The following is a description of a gene set: Human Gene Set: GOBP_PLATELET_DENSE_GRANULE_ORGANIZATION species: Homo sapiens A process that is carried out at the cellular level which results in the assembly, arrangement of constituent parts, or disassembly of a platelet dense granule. A platelet dense granule is an electron-dense granule occurring in blood platelets that stores and secretes adenosine nucleotides and serotonin. They contain a highly condensed core consisting of serotonin, histamine, calcium, magnesium, ATP, ADP, pyrophosphate and membrane lysosomal proteins., and this is the list of marker genes: HPS6, AP3S2, AP3S1, HPS4, AP1S1, AP1B1, AP1S3, HPS3, BLOC1S1, AP3B1, RAB38, F2R, F2RL3, AP1G1, HPS1, AP3D1, ABCA1, AP3M1, AP1S2, HPS5, DTNBP1, BLOC1S2, BLOC1S3, AP1M1, SLC35D3